The following is a description of a gene set: studied in species Homo sapiens Human Gene Set: GOBP_MYOBLAST_PROLIFERATION The multiplication or reproduction of myoblasts, resulting in the expansion of a myoblast cell population. A myoblast is a mononucleate cell type that, by fusion with other myoblasts, gives rise to the myotubes that eventually develop into skeletal muscle fibers., and this is the list of marker genes: IGF1, ABL1, MYOD1, SIX1, ATF2, PPARD, KRAS, KCNA5, FES, GPX1, ATOH8, MALAT1, HGF, MIR1-1, MIR10A, ZNF609, KLHL41, MIR133A1, PAX7, SOX15, FGF7, MIR204, MIR199A1, MIR133B, PAXBP1, GATA6, CTNNB1, FOS, FGFBP1, MEIS2 (Meis homeobox 2), MIR134, MEGF10, MIR499A, MSTN (myostatin)